Given this list of marker genes Slc22a8, Slco1b2, Slc22a2, Abcc4, Slc22a1, Slco2a1, Slc22a6, Slc22a7, Slco2b1, Slco4a1, Slco3a1, here is a description of the gene set: Enables the transfer of prostaglandins from one side of a membrane to the other. A prostaglandin is any of a group of biologically active metabolites which contain a cyclopentane ring due to the formation of a bond between two carbons of a fatty acid. They have a wide range of biological activities. Mouse Gene Set: GOMF_PROSTAGLANDIN_TRANSMEMBRANE_TRANSPORTER_ACTIVITY species: Mus musculus